Given this list of marker genes Npy2r, Eno1, Kit, Adra1a, Nppa, F2r, Chga, Atp1a1, Ptgs2, Gper1, Ccn2, Ptger3, Tacr2, Lck, Itga2, Rgs2, Pawr, Ghsr, Ptafr, Mylk2, Oxtr (oxytocin receptor), Spx, Cacna1c, Oxt, Smtn, Sphk1, Ace2, Adra2b, Prok2, Edn3, Srf, Cacng1, Myocd, Map2k1, Nmu (neuromedin U), Abat, Npnt, Edn1, Rhoa, Trpv4, Hsp90aa1, Cttn, Eno1b, Cacna1s, Kcnq1, Tacr3, Atp2a1, Chrm3, Tacr1, Cacnb2, Cacnb1, Ada, Ptgs1, Actn3, Edn2, Tbxa2r, Ucn, Ghrl, here is a description of the gene set: species: Mus musculus Mouse Gene Set: GOBP_POSITIVE_REGULATION_OF_MUSCLE_CONTRACTION Any process that activates or increases the frequency, rate or extent of muscle contraction.